The following is a description of a gene set: Genes down-regulated in comparsion of sfActCD4TGF versus ActCD4TGF (see Fig. 1 in the paper for details). Human Gene Set: GSE7460_FOXP3_MUT_VS_WT_ACT_WITH_TGFB_TCONV_DN studied in species Homo sapiens from publication Hill JA, Feuerer M, Tash K, Haxhinasto S, Perez J, Melamed R, Mathis D, Benoist C (PMID 18024188) The transcription factor Foxp3 is usually considered the master regulator for the CD4+CD25+, and this is the list of marker genes: UBXN6, FGF13, CAPG, DNAAF9, FBXO32, NUCB2 (NCBI Gene Id 4925), ZMYM5, APPL2, SLC17A9, TLR1, LRRC57, SLC43A2, FAM98C, UBP1, NAAA, ACCS, MFGE8, CHD9, ALDH6A1, GPHN, UBE2J1, HAL, S1PR1, DSTYK, FAM120AOS, KMT5B, ARMC3, AMPD1, SESN1, ARHGEF10, LEF1, PDLIM4, ANKLE2, SLC49A4, NRP1, ADPGK, MBP, FAM117B, TREML2, ANKRD50 (NCBI Gene Id 57182), CEP97, RESP18, LRIG1, B9D2, NTRK3, HECTD4, ZNF280D, SNX30, SH3BGRL2, PCNX1, ADGRE5, ACVR1C, DUSP7, RBM33, AKAP8L, IKBKB, KIAA0930, PRKCA, TMEM219, TUBGCP4, TMEM131, OAZ2, PODXL, SYCP2L (synaptonemal complex protein 2 like), IPCEF1, DGKD, WDR82, USF2, MFHAS1, SMOX, KLC4, TRAT1, PITPNC1, CALCRL, IL17RA, RERE, STAT5B, KDM7A, CD40, TECPR1, IL27RA, SHE, PRRC2B, CARNS1, RASSF3, ESR1, RAP1GAP2, GATA1, CDON, SNN, CFTR, ADAMTS6, HLA-DOA, MGST2, ZBTB20, SENP7, GRAMD4, KLF7, COQ8A, SLC25A51 (NCBI Gene Id 92014), SSH2, PPDPF, TASP1, TBC1D16, MTMR3 (myotubularin related protein 3), MORC1, USP27X (ubiquitin specific peptidase 27 X-linked), HLA-DOB, TBC1D17, MAML1, C14orf28, RECK, SH3BP5, PINK1, IFT88, CBX7, SLC12A7 (solute carrier family 12 member 7), CAST, TNFAIP8L2, EPS15, ARID1B, SOCS2, CPE, RABGAP1L, TCP11L2, ENDOV, ERBB3 (NCBI Gene Id 619500), HPCAL1, TRIB2, UBASH3B, JMY, RAMP1, STK38, TAX1BP3, ARHGEF4, NFIX, ACAA2, TCF4, ZNF217, CERK, DOCK4, XPA, CRADD, ITIH5, NIPAL1, SMURF1, UBN2, ARL2BP, ARHGAP15 (Rho GTPase activating protein 15), RFLNB, USH1C, SH3PXD2A, DRC1, RIPOR2, CCDC88C, PXMP4, EXT1, MTUS1, ACSS1, CACNA2D4, AP1M2 (adaptor related protein complex 1 subunit mu 2), SARDH, NIBAN2, UBXN11, SMAD3, ARHGEF3, PDIA2, AMIGO2, IGFBP4, KLF2, OSBPL2, SQOR, SMAD4, CAMK2N1, MAF1, MPND, SESTD1, MAP4K4, SLC50A1, NBDY, FOXP3 (NCBI Gene Id 50943), XIST, FRAT2, MCL1, PARM1, RAB33B, ADCY9, ITGA4, KDM6A, NREP, STAMBPL1, RHOH, SELL, UNC80, WIPI2, IKBKE, THRAP3, IL6ST, SLC44A1, CYP4V2